Given this list of marker genes HSPA8, YWHAE, HSPA14, NUP98, FKBP4, SIRT1, EP300 (NCBI Gene Id 2033), HSPA4, MRPL18, NUP160, NUP153, HSPA6, RPS19BP1, COL4A6, HSPH1, ATM, CCAR2, AKT1S1, NUP42, NUP58, SEH1L, RPTOR, NUP62, NUP205, HSPB8, BAG2, NUP214, NUP88, DEDD2, NUP85, NUP133, HSPA13, HSPA1A, MAPK3, NUP37, DNAJC2, GSK3B, CRYAB, CAMK2B, BAG4, HSPB2, AAAS, NUP155, HSPB1, RPA2, CRYBA4, MLST8, UBB, NUP210, POM121, CAMK2G, NDC1, HSBP1, BAG3, RLN1 (NCBI Gene Id 6013), NUP107, SERPINH1, DNAJC7, RPA3, RPA1, HSP90AA1, MAPKAPK2, HSPA12B, HSPA2, NUP188, RAE1, TPR, HSPA4L, NUP93, VCP, TNFRSF21, HSF1, PTGES3, MAPK1, ATR, HSPA1B, HSPA12A, BAG1, BAG5, ST13, CAMK2D, NUP50, HDAC6, RANBP2, DNAJB1, NUP54, HSPA9, HSP90AB1, NUP35, CAMK2A, NUP43, HSPA1L, POM121C, EEF1A1, GML, HSPA5, HIKESHI, CREBBP, SEC13, MTOR, DNAJB6, here is a description of the gene set: Human Gene Set: REACTOME_CELLULAR_RESPONSE_TO_HEAT_STRESS species: Homo sapiens Cellular response to heat stress